Given this list of marker genes Abcb4, Idi1, Smarcc1, Prdx1, Gnpat, Pabpc1, Aldh1a1, Pex14, Abcd1, Hao2, Abcc5, Cln6, Dhcr24, Hsd11b2, Pex5, Ctps1 (NCBI Gene Id 51797), Top2a, Scp2, Crabp2, Slc23a2, Abcc8, Crat, Vps4b, Tspo, Alb, Cadm1, Cat, Bcl10, Elovl5, Dhrs3, Mvp, Pex11a, Hsd3b7, Sema3c, Slc27a2, Atxn1 (ataxin 1), Retsat, Slc25a17, Sod1, Abcb1a, Gstk1 (NCBI Gene Id 99356), Siah1a, Isoc1, Rdh11, Acaa1a, Mlycd, Fis1, Pex2, Ywhah, Nudt19, Sult2b1, Prdx5, Cnbp, Ercc1, Cdk7, Abcd3, Rxrg, Ide, Aldh9a1, Ercc3, Dlg4, Ephx2, Idh2, Nr1i2, Itgb1bp1, Fads1, Ttr, Cacna1b, Acot8, Serpina6, Ech1, Pex13, Hras, Acsl1, Eci2, Cel, Idh1, Abcb9, Crabp1, Abcd2, Pex11b, Hsd17b11, Esr2, Slc25a4, Acsl4, Msh2, Pex6, Fabp6, Lonp2, Fdps, Slc25a19, Sts, Slc35b2 (NCBI Gene Id 73836), Acsl5, Scgb1a1 (secretoglobin, family 1A, member 1), Ehhadh, Cln8, Sod2, Dio1, Ctbp1, Hsd17b4, Hmgcl, Acox1, here is a description of the gene set: Mouse Gene Set: HALLMARK_PEROXISOME from publication Howe DG, Blake JA, Bradford YM, Bult CJ, Calvi BR, Engel SR, Kadin JA, Kaufman TC, Kishore R, Laulederkind SJF, Lewis SE, Moxon SAT, Richardson JE, Smith C (PMID 30224793) species: Mus musculus Mouse genes annotated to HALLMARK_PEROXISOME based on orthology mappings provided by the Alliance Genome Consortium